Given this list of marker genes PIGS, PPIL4, SAR1A, ATP2A2, TRIM8, PLA2G15, SLC30A1, POLR3F, CD83, USP30, UBAC1, FMNL1, UBAP2L, RAP2B, PGS1, LPP, PPP1R14B, VPS37B, PPP1R12B, CORO7, MIDN, RIN3, HMGXB4, ZNF805, CFL2, NEK3, DDX19B, RILPL2, ANKS1A, RNF168, RNF10, ABCA13, ATG9A (autophagy related 9A), RNASEH1, GTPBP1, RBSN, DENND1A, XPO7, SH2B3, ADO, FASTKD5, PPP3R1, FCHSD2, MADD, ZNF746, FOXP1-IT1, MAP3K2, SUPT5H, PIK3R5, RFPL3S, GRB2, HYMAI, FBXL12, MAP6D1, SNN, KMT5A, NAPG, ULK1, DNAJC3, SDE2, IBA57, ITGAX, EDEM1, MEF2D, TACC1, SLC25A28, RBM33, SLC36A4, ZBTB26, USP3, ARID5A, RCC2, LRRC57, SLC16A5, NBEAL2, MNT, MAPKAPK2, PPM1A, KATNIP, WBP11, B3GNT7, CACUL1 (NCBI Gene Id 143384), GLTP, TRIM11, DCLRE1C, KLHDC2, RELA, GRPEL1, HGS, DSTYK, ABHD13, PWWP2B, VPS18, MAFG, ZBED4, SIK1, ZNF8, ZDHHC3, ZNF766, DHX35, CKAP4, ZBTB39, ZNF317, NR4A2, BTBD18, BLTP3A, RNF139, WBP2, NPEPL1, WASL, STON1, PHF21A, ACVR1B, USP22, EFHD2, USP42, BAP1, KCTD20, MTMR3, C2orf49, AKAP8, USP24, NXF1, GZF1, ZDHHC7, CRTC2, GPATCH2L, ZBTB34, RAD23B, AKT1S1, NFIL3, NCOR2, LINC02035, XPNPEP1, RMC1, CTNNB1, GNE, SPATA2, PITPNA, ZBTB2, PAFAH1B2, SQSTM1, METRNL, IRAK1, CRK, DIS3, ZBTB10, ZNF3, KDM5B, PXN, DAZAP2, ARAF, GOSR2, VPS11, ATXN1L, ATG14, ZNF787, CAPN1, SAT2, FHIP2A, MRGBP, FOXK2, NUDT15, SERTAD2, SMAD7, ATPAF2, CCDC69, RUNX3, PHLPP1, MAP7D1, C6orf136, EBLN2 (NCBI Gene Id 55096), CALU, CEBPG, NECAP1, MYO19, ABL1, SLC26A6, CUX1, HBEGF, MAPKAP1, CTSK, TNFRSF1B, VPS33B, ARF3, KLF11, PURB, BRAP, SUSD6, TMEM184B, here is a description of the gene set: Genes up-regulated in comparison of unstimulated peripheral blood mononuclear cells (PBMC) versus PBMC 21 days after stimulation with YF17D vaccine. The immune responses generated by YF-17D by profiling genes in 25 vaccine recipients were accessed at days 1, 3, 7, and 21 post-vaccination compared to pre-vaccination in PBMCs. The immune responses generated by YF-17D by profiling genes in 25 vaccine recipients were accessed at days 1, 3, 7, and 21 post-vaccination compared to pre-vaccination in PBMCs. from publication Querec TD, Akondy RS, Lee EK, Cao W, Nakaya HI, Teuwen D, Pirani A, Gernert K, Deng J, Marzolf B, Kennedy K, Wu H, Bennouna S, Oluoch H, Miller J, Vencio RZ, Mulligan M, Aderem A, Ahmed R, Pulendran B (PMID 19029902) Human Gene Set: GSE13485_CTRL_VS_DAY21_YF17D_VACCINE_PBMC_UP studied in species Homo sapiens